The following is a description of a gene set: Mouse Gene Set: GOBP_PRIMITIVE_HEMOPOIESIS studied in species Mus musculus A first transient wave of blood cell production that, in vertebrates, gives rise to erythrocytes (red blood cells) and myeloid cells., and this is the list of marker genes: Smarca4, Stk4, Tal1, Zfpm1, Gata1, Hscb, Kdm1a, Vegfa, Stk3, Ldb1, Thoc5, Gata2